The following is a description of a gene set: electronically inferred by orthology from the curated human pathway part of: Integrin signaling studied in species Mus musculus Reactome Pathway: p130Cas linkage to MAPK signaling for integrins This event has been computationally inferred from an event that has been demonstrated in another species.<p>The inference is based on the homology mapping from PANTHER. Briefly, reactions for which all involved PhysicalEntities (in input, output and catalyst) have a mapped orthologue/paralogue (for complexes at least 75% of components must have a mapping) are inferred to the other species., and this is the list of marker genes: Itga2b, Tln1, Fgg, Apbb1ip, Bcar1, Crk, Ptk2